Given this list of marker genes GK2, CLUAP1, CYLC2, MTOR, SYCP2, BRD1, CDKN3, PPP1R2C, NUP155, NF2, PPFIA1, SYCP1, BRDT, ADAM2, OIP5, TLE4, TEKT2, CDK1, MLLT10, ZPBP, SPATA31A7, IDE, TULP2, BUB1B, HMMR, ZNF165, AURKA, GAGE1, DCAF1, ZNRF4, SSX2, NXT2, CCNB1, GK, CLTCL1, BRAF, SFMBT1, NCAPH, PMS1, RFPL3S, CCT6B, PRKAR2A, TOPBP1, EPPIN, PSMG1, TTLL5, GPR135, ITCH, NEK2, BUB1, STAM2, ABCB6, DAZL, TMF1, EZH2, ACRV1, PALS2, RBMXL2, SMCP (sperm mitochondria associated cysteine rich protein), PRAME, ART3, RASSF1, MLF1, HSF2BP, GRK4, SOCS7, PHKG2, DBF4, CCNB2, IRGC, RAD17, TTK, TSPY1, SOX5, RPL39L, RFC4 (replication factor C subunit 4), KIF2C, COIL, CAMP (NCBI Gene Id 820), PIWIL1, here is a description of the gene set: from publication Su AI, Cooke MP, Ching KA, Hakak Y, Walker JR, Wiltshire T, Orth AP, Vega RG, Sapinoso LM, Moqrich A, Patapoutian A, Hampton GM, Schultz PG, Hogenesch JB (PMID 11904358) High-throughput gene expression profiling has become an important tool for investigating transcriptional activity in a variety of biological samples. To date, the vast majority of these experiments have focused on specific biological processes and perturbations. Here, we have generated and analyzed gene expression from a set of samples spanning a broad range of biological conditions. Specifically, we profiled gene expression from 91 human and mouse samples across a diverse array of tissues, organs, and cell lines. Because these samples predominantly come from the normal physiological state in the human and mouse, this dataset represents a preliminary, but substantial, description of the normal mammalian transcriptome. We have used this dataset to illustrate methods of mining these data, and to reveal insights into molecular and physiological gene function, mechanisms of transcriptional regulation, disease etiology, and comparative genomics. Finally, to allow the scientific community to use this resource, we have built a free and publicly accessible website (http://expression.gnf.org) that integrates data visualization and curation of current gene annotations. Genes up-regulated specifically in human testis tissue. Human Gene Set: SU_TESTIS species: Homo sapiens